The following is a description of a gene set: species: Homo sapiens Neighborhood of CRKL Neighborhood of CRKL v-crk sarcoma virus CT10 oncogene homolog (avian)-like in the GCM expression compendium Human Gene Set: GCM_CRKL, and this is the list of marker genes: WSB1, BMPR2, DYNC1I2, TRO (trophinin), GSK3B, UBE2W, CHTOP, REPIN1, RMDN3, MTMR2, FAM168B, SPIRE1, DDX17, IPO5, SPRED2, SELENOI, CALM1, NAA30 (NCBI Gene Id 122830), IPO7, KDM3B, HERC2, OCIAD1, ALKBH5, KLHL42, ZNF84, NAB1, FAN1, ANKFY1, MARF1, ARL8B, NGRN, MYO10, RIMOC1, ADO, OAZ2, RALGAPA1, TSR1, STX12, GOLGA7, TEX261, ABI2, ZNF286A, IL6ST, UBE2H, DYNC1H1, GPR107, MAP4K4 (NCBI Gene Id 9448), CS, TANC2, CRKL, ZFP14, RTN4, PRPF8, XPO6, POLDIP3, TMEM30A, MTMR4, UBE2K, HMG20A, TSNAX, PACS2, GTF2A1, ANKRD17, C2CD3